Given this list of marker genes TAS2R38, SCN4B, SCNN1B, ITPR3 (inositol 1,4,5-trisphosphate receptor type 3), TAS2R41, TAS1R2, TAS2R7, TAS2R3, TAS1R1, CALHM1, TAS2R20, OTOP1, PLCB2, GNAT3, SCN3A, TAS2R39, GRM1, TAS2R31, GRM4, TAS2R8, TAS2R50 (taste 2 receptor member 50), SCNN1A, TAS2R43, GNB3, TAS2R40, SCN2B, TAS2R1, TAS2R5, TAS1R3, SCNN1D, TRPM4, KCNJ2, TAS2R14, GNG13, SCN9A (sodium voltage-gated channel alpha subunit 9), GNB1, TAS2R16 (NCBI Gene Id 50833), TAS2R30, TRPM5, TAS2R4, SCNN1G, CALHM3, TAS2R10, TAS2R46, SCN1B, SCN2A, TAS2R13, here is a description of the gene set: species: Homo sapiens Taste buds contain at least 3 types of cells: type I cells appear to have a support (glial-like) function; type II cells are responsible for tasting sweet compounds, bitter compounds, and umami (savoury, amino acid) compounds; and type III cells are responsible for tasting sour (acidic) compounds. Recently identified sodium sensing cells expressing the epithelial sodium channel (ENaC) and POU2F3 are thought to be responsible for tasting low concentrations of salt and may be a subset of type II cells or a novel type of taste cell. High concentrations of salt appear to be detected by both type II and type III cells.<br>Receptors for sweet compounds, bitter compounds, and umami compounds contain an intracellular domain, transmembrane domains, and an extracellular domain that binds the ligand. The extracellular domains of receptors for sweet and umami ligands have a distinctive "venus flytrap"-shaped domain. Upon binding ligand, sweet taste receptors (TAS1R2:TAS1R3 heterodimers), bitter taste receptors (TAS2R class receptors), and umami receptors (TAS1R1:TAS1R3 heterodimers) then signal through a common downstream pathway: the receptor-ligand complex activates an associated heterotrimeric G protein complex (GNAT3:GNB1 or GNB3:GNG13) to exchange GDP for GTP, the heterotrimeric G protein complex dissociates and the resulting GNB1,3:GNG13 complex activates Phospholipase C beta-2 (PLCB2) which hydrolyzes phosphoinositol 4,5-bisphosphate (PI(4,5)P2) to yield inositol 1,4,5-trisphosphate (I(1,4,5)P3) and diacylglycerol (DAG). I(1,4,5)P3 binds and activates ITPR3 to release calcium ions from the endoplasmic reticulum into the cytosol. Cytosolic Ca2+ causes TRPM5 sodium channels to open and depolarize the cell. SCN2A, SCN3A, and SCN9A sodium channels also appear to augment the depolarization. Depolarization causes opening of CALHM1:CALHM3 channels which transport ATP from the cytosol to the extracellular region. ATP then acts as a neurotransmitter in the taste sensing system.<br>Alternative pathways exist for sensing sugars and glutamate, as evidenced by residual signaling activity in the absence of TAS1R1 or TAS1R3. Glutamate is sensed by the glutamate receptors GRM1 (mGluR1) and GRM4 (mGluR4) expressed in type II taste cells. GRM1 and GRM4 activate calcium channels by an incompletely characterized mechanism that probably involves heterotrimeric G proteins. Glucose may be sensed by a pathway comprising transport into type II taste cells via the glucose transporters SGLT1 and GLUT4, generation of ATP, and inhibition of KATP potassium channels by ATP.<br>Protons (H+ ions) from acidic compounds translocate from the extracellular region to the cytosol of type III taste cells through the OTOP1 channel. Weak acids such as acetic acid and citric acid are also able to enter type III cells by diffusing through the membrane in their protonated, uncharged forms, Once in the cytosol, the H+ ions inhibit KCNJ2 inwardly rectifying potassium channels, depolarizing the cell. The H+ ions may also open unidentified sodium channels to further depolarize the cell. Depolarization causes exocytosis of the neurotransmitters serotonin (5-HT) and gamma-aminobutyric acid (GABA).<br>Low concentrations of salt appear to be sensed in specific salt-sensing cells that may be a subset of type II cells. Low concentrations of salt are believed to enter the cell through an epithelial sodium channel (ENaC, SCNN) and the ability to taste low concentrations of salt is dependent on the SCNN1A pore-containing subunit of the SCNN complex in mice. Human taste cells express both SCNN1A and SCNN1D pore-containing subunits. The composition of other subunits of the complex is less certain. The transport of sodium ions (Na+) into the cells depolarizes the plasma membrane and eventually leads to opening of CALHM1:CALHM3 channels which transport ATP from the cytosol to the extracellular region. Reactome Pathway: Sensory perception of taste part of: Sensory Perception